Given this list of marker genes PTGR2, CBR1, PTGES, PTGES2, TBXAS1, PTGS2, PRXL2B, PTGIS, CYP8B1, PTGS1, AKR1C3, PTGES3, PTGDS, HPGD, HPGDS, here is a description of the gene set: Synthesis of Prostaglandins (PG) and Thromboxanes (TX) species: Homo sapiens Human Gene Set: REACTOME_SYNTHESIS_OF_PROSTAGLANDINS_PG_AND_THROMBOXANES_TX